Given this list of marker genes STX1A, ELN, STAT3, LBR, IGKC, GTF2I, CTLA4, WFS1, GTF2IRD1, FOXP3, SKIC3, RFC2, AIRE, CDH1, LIMK1, CISD2, METTL27, SYK, FKBP6, GBA1, EIF4H, IPO8 (importin 8), CASP10, ABCC2, DEF6, NCF1, LRBA, IGHG2, PLA2G4A, NFKB1, VPS37D, DNAJC30, TMEM270, BUD23, CLIP2, FASLG, ARID1B, IFIH1, FOCAD, ELF4, SKIC2, CARD8, TBL2, GTF2IRD2, RIPK1, BAZ1B, FAS (Fas cell surface death receptor), here is a description of the gene set: studied in species Homo sapiens An abnormality of the gastric mucous membrane. Human Gene Set: HP_ABNORMAL_GASTRIC_MUCOSA_MORPHOLOGY Abnormal gastric mucosa morphology